Given this list of marker genes Dnajc3, Nck1, Eif4g1, D1Pas1, Nck2, Ddx3x, here is a description of the gene set: Mouse Gene Set: GOBP_POSITIVE_REGULATION_OF_TRANSLATION_IN_RESPONSE_TO_ENDOPLASMIC_RETICULUM_STRESS Any process that activates, or increases the frequency, rate or extent of translation as a result of endoplasmic reticulum stress. species: Mus musculus